Given this list of marker genes gyrA, gyrB, mrcB, qnr, 16S rRNA, rrsA, here is a description of the gene set: species: Homo sapiens Antimicrobial compounds kill microorganisms or inhibit their growth, either in the host, outside on the skin (antiseptics), or in the environment (disinfectants). In the host they are named after the target symbiont, for example antibiotics, antifungals, and antiparasitics. It suffices to permanently stop an essential pathway in the symbiont to kill it. Broad spectrum antimicrobials usually target a conserved pathway like protein synthesis or cell wall construction, in order to affect a whole taxonomic group (Arenz & Wilson 2016, Barry et al. 2007, Green 2002). Reactome Pathway: Action of antimicrobials part of: Action of antimicrobials and antimicrobial resistance